The following is a description of a gene set: part of: Class A/1 (Rhodopsin-like receptors) This event has been computationally inferred from an event that has been demonstrated in another species.<p>The inference is based on the homology mapping from PANTHER. Briefly, reactions for which all involved PhysicalEntities (in input, output and catalyst) have a mapped orthologue/paralogue (for complexes at least 75% of components must have a mapping) are inferred to the other species. Reactome Pathway: Hydroxycarboxylic acid-binding receptors studied in species Mus musculus electronically inferred by orthology from the curated human pathway, and this is the list of marker genes: Hcar1, Hcar2